Given this list of marker genes LY96, FAP, NOD1, NOD2, NLRP3, CD1D, PGLYRP2, LBP, PTPRJ, NR4A1, DACH1, NAIP, NLRC4, C4B, TLR6, CLEC7A, TLR4, HLA-A, SSC5D, SRPX, PGLYRP1, HLA-B, TSPO, CDHR2, PAK1, TLR9, ATF2, TLR1, CLEC6A, PGLYRP4, TLR2, CRTAM, HLA-DRB1, PGLYRP3, SMO, SCARB1, TREM2, here is a description of the gene set: The series of events in which a biotic stimulus, one caused or produced by a living organism, is received and converted into a molecular signal. studied in species Homo sapiens Human Gene Set: GOBP_DETECTION_OF_BIOTIC_STIMULUS